The following is a description of a gene set: part of: Regulation of CDH1 Gene Transcription studied in species Mus musculus This event has been computationally inferred from an event that has been demonstrated in another species.<p>The inference is based on the homology mapping from PANTHER. Briefly, reactions for which all involved PhysicalEntities (in input, output and catalyst) have a mapped orthologue/paralogue (for complexes at least 75% of components must have a mapping) are inferred to the other species. Reactome Pathway: Negative Regulation of CDH1 Gene Transcription electronically inferred by orthology from the curated human pathway, and this is the list of marker genes: Smarca4 (SWI/SNF related, matrix associated, actin dependent regulator of chromatin, subfamily a, member 4), H4c18, H3c8, H2ac24, H2ac22, H2bc13, H2ac15, H2bc3, H2ac19, H3c4, Kdm1a, H4c8, H2bc7, H3c7 (H3 clustered histone 7), H4c17, H2bc12, H2bc27, H2ac10, H2ac7, H3c10, H4c11, H2ac23, H2ac6, H2ac11, Rbbp4, H2ac12, H3c1, H4c9, H4c4, H2ax, H2az2, H3c2, H4c1, H2ac8, H2bc22, H2ac20, H3c6, H3c3 (H3 clustered histone 3), H2ac1, H2bc8, H4c3, H4c14, H4c6, H3c11, H2ac4, H3c15, H4c2, H3f3a, Dnttip1, Ezh2, H2bc11, H2bc9, H2ac13, H2bc15, Rbbp7, H4c12, H2bc1, Twist1, H3c13, Zmym2